Given this list of marker genes TNFRSF10A, FADD, CASP8, CFLAR, CASP10, TNFSF10, TNFRSF10D, TNFRSF10B, here is a description of the gene set: Human Gene Set: REACTOME_TRAIL_SIGNALING species: Homo sapiens TRAIL signaling